The following is a description of a gene set: To identify genes linked to normal plasma cell (PC) differentiation and to classify multiple myeloma (MM) with respect to the expression patterns of these genes, we analyzed global mRNA expression in CD19-enriched B cells (BCs) from 7 tonsils, CD138-enriched PCs from 11 tonsils, 31 normal bone marrow samples, and 74 MM bone marrow samples using microarrays interrogating genes. Hierarchical clustering analyses with genes clearly segregated the 4 cell types, and chi-square and Wilcoxin rank sum tests (P <.0005) identified 359 and 500 previously defined and novel genes that distinguish tonsil BCs from tonsil PCs (early differentiation genes), and tonsil PCs from bone marrow PCs (late differentiation genes), respectively. MM as a whole was found to have dramatically variable expression of EDGs and LDGs, and one-way analysis of variance (ANOVA) was used to identify the most variable EDGs (vEDGs) and LDGs (v1LDG and v2LDG). Hierarchical cluster analysis with these genes revealed that previously defined MM gene expression subgroups (MM1-MM4) could be linked to one of the 3 normal cell types. Clustering with 30 vEDGs revealed that 13 of 18 MM4 cases clustered with tonsil BCs (P =.000 05), whereas 14 of 15 MM3 cases clustered with tonsil PCs when using 50 v1LDG (P =.000 008), and 14 of 20 MM2 cases clustered with bone marrow PCs when using 50 v2LDG (P =.000 09). MM1 showed no significant linkage with normal cell types studied. Thus, genes whose expression is linked to distinct transitions in late-stage B-cell differentiation can be used to classify MM. from publication Zhan F, Tian E, Bumm K, Smith R, Barlogie B, Shaughnessy J Jr (PMID 12393520) The v1LDG up-regulated set: most variable late differentiation genes (LDG) with similar expression patterns in tonsil plasma cells (TPC) and multiple myeloma (MM) samples. species: Homo sapiens Human Gene Set: ZHAN_V1_LATE_DIFFERENTIATION_GENES_UP, and this is the list of marker genes: SPINT2, TCN2, CXCL12, TIAM1 (TIAM Rac1 associated GEF 1), PPBP, NAGLU, AMPD3, ATP6V1B2, PF4, BIRC3, KIAA0513, CST3, PRCP, DYNLT1, IFNGR2, ITGA6, RALY, TNFAIP3, NUCB2, CAT, HSD17B8, TIMP2, APLP2, CXCR4, S100A4, MARCKS, RHOA, RB1, FUCA1, FCGRT, B4GALT1, DEFA1, SELENOP